The following is a description of a gene set: C57Bl/6 wild-type and STAT6 KO mice were used to study PPARg and IL-4 signaling. Bone marrow of 3 mice per group was isolated and differentiated to macrophages with M-CSF (20 ng/ml). 20 ng/ml IL-4 was used to induce alternative macrophage activation and 1 uM Rosiglitazone (RSG) was used to activate PPARg. From each mouse 4 samples were generated: 1. M-CSF, 2. M-CSF+RSG, 3. IL-4 and 4. IL-4+RSG. All compounds were added throughout the whole differentiation process, and frech media was added every other day. Control cells were treated with vehicle (DMSO:ethanol). After 10 days, RNA was isolated and gene expression profiles were analyzed using Mouse Genome 430 2.0 microarrays from Affymetrix. studied in species Homo sapiens from publication Szanto A, Balint BL, Nagy ZS, Barta E, Dezso B, Pap A, Szeles L, Poliska S, Oros M, Evans RM, Barak Y, Schwabe J, Nagy L (PMID 21093321) Human Gene Set: GSE25088_WT_VS_STAT6_KO_MACROPHAGE_ROSIGLITAZONE_AND_IL4_STIM_DN Genes down-regulated in bone marrow-derived macrophages treated with IL4 and rosiglitazone: wildtype versus STAT6 knockout., and this is the list of marker genes: BAG2, MAOA, CTSV, EID3, PAM16, ABHD14A, GLB1L, NCLN, CITED2, ADORA3, ASGR1, RNH1, NMRK1, CPT1A, ACVR2A, FAM43A, DYNC2I2, MSC, JAKMIP1, OSCAR, ICOS, ARL8A, BMI1, FZD3, SLC9A9, DTX1, SPMIP8, IGFBP7, SNHG16, RNPS1, PFDN4, TBC1D25, NEO1, IQCG, ACTA2, CHDH, NACC2, MT1F, PPP1R14C, GRK4, IL5, LIMA1, KIF5C, EMB, CTSB, OSGIN2, CPPED1, EOGT (NCBI Gene Id 79580), APOL4, SLC35E4, BLVRA, CD86, MT1X, GHRH, MRPL21, BPGM, UBXN10, LYRM1, SLC38A5, GTDC1, ARHGEF12, B9D2, FLYWCH2, TRIM47, IFNG, FXYD2, GPN1 (NCBI Gene Id 11321), PPT1, NAALADL1, RADX, INPP4B, CNBD2, CPQ, RNF157, DOCK9, TBX21, KCTD15, PRKAG2, PTGR3, SLC47A1, MX2, IFT22, SPATA2, SEL1L3, PMVK, SCPEP1, PIP5K1B, KCNC3, CPM, PLAC1, PTGDR2, CDKL2, CTSA, ZBED10P, GSTK1, COPZ2, SUPT5H, TEC, MYO5A, IL17A, MT1H, ANKS1B, IL17RB, STOM, AIM2, RENBP (renin binding protein), MPO, GALM, HSPA9, ANKRD35, YWHAQ, DSTNP2 (DSTN pseudogene 2), TMEM147, GLDC, FXN, LDOC1, PNMA1, ID1, CIZ1, FAM110C, AMD1, AGFG2, GPR183, SGCB (sarcoglycan beta), EVI5, GALNT4, GPRC5B, OXCT1, CD70, GK3, GJB6, SELENOK, PIAS2, MT2A, FLVCR2, MYG1, IQGAP2, FAM169A, GLMP, RUNX1, SLC22A17, CISD3, GLIS3, CD99, TBKBP1, BEX5, CX3CL1, HCG4, IL1R2, FAM124A, COL6A3, RUNX2, CDK2AP2, NAPSA, KCNAB2 (NCBI Gene Id 8514), MYOF, ZFYVE28, LMNA, TRIM69, ACAT1, MAPK6, BIK, TUBA3D, MAP3K21, MT1HL1, TSPO, RCAN2, MYL9 (NCBI Gene Id 10398), MORN1, PAQR6, CADM1, MT1G, F5, AURKAIP1, PTPN13, BATF, GBP1, CCL4, PITX3, SNRPC, KIF21A, TRERF1, TRABD2A, ABHD17C, UBE2A, KIR2DS4, NXF5, SEMA6D, SULT1B1, TXN2, GPAT3, KIF9, RGS9, RAB27A, GAREM2, AGAP3